The following is a description of a gene set: species: Homo sapiens Fibronectin matrix formation Human Gene Set: REACTOME_FIBRONECTIN_MATRIX_FORMATION, and this is the list of marker genes: CEACAM8, ITGB1, ITGA5, CEACAM6, CEACAM1, FN1